The following is a description of a gene set: Catalysis of the transfer of the amide nitrogen of glutamine to a substrate. Usually composed of two subunits or domains, one that first hydrolyzes glutamine, and then transfers the resulting ammonia to the second subunit (or domain), where it acts as a source of nitrogen. studied in species Mus musculus Mouse Gene Set: GOMF_CARBON_NITROGEN_LIGASE_ACTIVITY_WITH_GLUTAMINE_AS_AMIDO_N_DONOR, and this is the list of marker genes: Pfas, Cps1, Qrsl1, Nadsyn1, Asnsd1, Asns, Gatb, Gatc, Gmps, Cad